Given this list of marker genes Avpr1b (NCBI Gene Id 26361), Avpr1a (NCBI Gene Id 54140), Avp, Oxtr, Avpr2, Oxt, here is a description of the gene set: Vasopressin-like receptors species: Mus musculus Mouse Gene Set: REACTOME_VASOPRESSIN_LIKE_RECEPTORS